The following is a description of a gene set: A structural anomaly of the ciliary body. Abnormal ciliary body morphology Human Gene Set: HP_ABNORMAL_CILIARY_BODY_MORPHOLOGY studied in species Homo sapiens, and this is the list of marker genes: LAMB2, SF3B1, BAP1, GNAQ, GNA11, CYSLTR2